Given this list of marker genes SPOP, TBX1, CHRND, NIPBL (NIPBL cohesin loading factor), CIROP, IFT27, CHRNG, KDM6A, TRAF7, TBX5, NOTCH1, NR2F2, GATA5, KMT2D, WT1, PAH, PKD1L1, GATA4, B3GLCT (NCBI Gene Id 145173), PLXND1, DPYSL5, SMAD6, CDK8, ARHGAP31, DVL3, FOXF1, NADSYN1, MYRF, GNB2, WASHC5, GJA1, STAG2, GATA6, EP300, MKKS, H3-3B, CFAP53, HAAO, TMEM218, CCDC22, COQ4 (coenzyme Q4), MCTP2, CPLANE1, NKX2-5, FLI1, VPS35L, KYNU, CHRNA1, DTNA, CREBBP, ZIC3, DAW1, CTU2, DEPDC5, here is a description of the gene set: Human Gene Set: HP_HYPOPLASTIC_HEART species: Homo sapiens Hypoplastic heart